Given this list of marker genes OXCT1, OXCT2, ACAT1, BDH1, here is a description of the gene set: The levels of acetone in ketone bodies are much lower than those of acetoacetic acid and beta-hydroxybutyric acid. Acetone cannot be converted back to acetyl-CoA, and is excreted in urine, or breathed out through the lungs. Extrahepatic tissues utilize ketone bodies by converting the beta-hydroxybutyrate successively to acetoacetate, acetoacetatyl-CoA, finally to acetyl-CoA. species: Homo sapiens Reactome Pathway: Utilization of Ketone Bodies part of: Ketone body metabolism